Given this list of marker genes TRIM8, USP16, MED30, PSIP1, TRIM5, BRD7, DDX17, CCAR1, UTF1, NFKBIB, CITED2, SMARCD2, CD274, TP53BP1, ACTN4, PAGE4 (PAGE family member 4), TRIM38, RBPMS, PHF2, ABL1, SMARCC1, CIITA, MYOCD, FHL5, HCFC1, BRD4, LPIN2, WBP2, PSMC3IP, ZIC3, XPC, RERE, APEX1, ING4, USP21, CCDC62, RBCK1, ZMIZ1, MRTFA, PUS1, MYCBP (MYC binding protein), LMO3, CTBP1, SNW1, MED14, TAF11, TOX3, MED24, NME2, MAML1, POU2AF2, MED26, NPM1, THRAP3, MED17, SLC30A9, IL31RA, CBFB, MED13L, NOTCH1, DTX1, TRIM22, TADA1 (transcriptional adaptor 1), DAXX (NCBI Gene Id 1616), BCL10, MRTFB, SMARCA2, BCL9L (NCBI Gene Id 283149), IRF4, CTNNB1, HMGB2, CNOT6, RAP2C, NCOA7, ARL2BP, FIZ1, BCL3, BRD8, PBXIP1, BRDT, LPIN1, KMT2C, LMO1, ACTL6B, PRDM16, CDCA4, MED12 (NCBI Gene Id 9968), SMARCA4, MID2, TAF6L, TMF1, ATXN7L3, KDM1A, VGLL2 (NCBI Gene Id 245806), ACTN1, TRIM37, EDF1, TRIM15, TDRD3, ABT1, NCOA1, NUCKS1, SMARCB1, SFR1 (NCBI Gene Id 119392), NCOA4, PSMD9, NCOA2, KAT8 (NCBI Gene Id 88034), MED27, ANKRD1, ASXL1, PRKCB, KAT5, MED13 (NCBI Gene Id 9969), MED23, HIPK2, SERTAD2, NRIP1, KAT2B, SMARCD1, MED1, DOT1L, KAT6A, ARGLU1, KAT6B, UBE2L3, SUPT7L, TRIM25, MTA2 (NCBI Gene Id 9219), RBM14, MYSM1 (Myb like, SWIRM and MPN domains 1), MED20, ZXDA, ATN1, TAF12, TRIM32 (tripartite motif containing 32), HYAL2, LPIN3, SMARCC2, WWTR1, CREBBP, PPARGC1B, PQBP1, TRIM21, CAMTA2, MED7, KMT2D, WWC1, NCOA3, TADA3, TAF9, AIP, ARID1B, CITED1, TRIM13, ZBED1, LDB1, ZFPM2, MAML3, HMGA1, MED4, DYRK1A, JADE1, NUPR1, SMARCE1, TRIM52, FUS, CTBP2, TRIP11, PKN1, UBE3A, SS18, CALCOCO1, CENPJ, TACC1, KDM5A, PER2, SUPT3H, TAF6, VGLL1 (NCBI Gene Id 51442), ENY2, RRP1B, MED21, WDR77, TRIM14, GTF2A1L, JUND, MMS19, JMY, TADA2B, BCL9, KMT2E, GPS2, CITED4, MED6, PPRC1, MAGED1, CRTC3, SETD3, TRIM24, APBB1, QKI, CCDC124, ACSS2, CARM1, ARID5B, PCBD1, RUVBL1, BIRC2, POU2AF3, DYRK1B (NCBI Gene Id 9149), PKM, CRTC1, ZXDC, TRERF1, MAK, MED16, USP22, MAML2, HCFC2, SSBP3 (single stranded DNA binding protein 3), MYT1L, SS18L1 (SS18L1 subunit of BAF chromatin remodeling complex), SMARCD3, WBP2NL, YAF2, DCAF6, TGFB1I1, LMO2, PRMT2, NACA, CRTC2, RIPK3, ARRB1, PPARGC1A, PMF1, ZMIZ2, CNOT9, SERTAD1, COPS5, TRIM28, PARK7, SIRT1, KDM4C, RNF14, HMGB1, JUP, TCERG1, TOX2 (TOX high mobility group box family member 2), PDLIM1, NUP98, SETD4, BUD31, DHX9, TAF5L, ARID1A, TRIM62, YAP1, CEBPZ, NPAT, ACTL6A, RNF20 (ring finger protein 20), MTDH (metadherin), SRA1, TRIM27, TRIM31, POU2AF1, TRIP4, TADA2A, NCOA6, SRCAP (Snf2 related CREBBP activator protein), TSC22D1, KAT2A, NIBAN2, MTA1, BRCA1, MTA3, WNT3A, SUB1, EP300, MED12L, HELZ2, PML, WWOX, ACTN2, here is a description of the gene set: A transcription coregulator activity that activates or increases the transcription of specific gene sets via binding to a DNA-binding transcription factor at a specific genomic locus, either on its own or as part of a complex. Coactivators often act by altering chromatin structure and modifications. For example, one class of transcription coactivators modifies chromatin structure through covalent modification of histones. A second class remodels the conformation of chromatin in an ATP-dependent fashion. A third class modulates interactions of DNA-bound DNA-binding transcription factors with other transcription coregulators. A fourth class of coactivator activity is the bridging of a DNA-binding transcription factor to the general (basal) transcription machinery. The Mediator complex, which bridges sequence-specific DNA binding transcription factors and RNA polymerase, is also a transcription coactivator. Human Gene Set: GOMF_TRANSCRIPTION_COACTIVATOR_ACTIVITY studied in species Homo sapiens